The following is a description of a gene set: The process whose specific outcome is the progression of the neural plate over time, from its formation to the mature structure. The neural plate is a flat, thickened layer of ectodermal cells. The underlying dorsal mesoderm signals the ectodermal cells above it to elongate into columnar neural plate cells. The neural plate subsequently develops into the neural tube, which gives rise to the central nervous system. Human Gene Set: GOBP_NEURAL_PLATE_DEVELOPMENT studied in species Homo sapiens, and this is the list of marker genes: C2CD3, ZIC3, NOG, DVL1, EPB41L5, VANGL2, DVL2, PTCH1, FGF8, CTNNB1